The following is a description of a gene set: species: Homo sapiens Reactome Pathway: RUNX1 regulates transcription of genes involved in WNT signaling part of: Transcriptional regulation by RUNX1 The RUNX1:CBFB complex directly regulates transcription of at least two components of WNT signaling. In association with its co-factor FOXP3, the RUNX1:CBFB complex stimulates transcription of the RSPO3 gene, encoding a WNT ligand that is implicated as a breast cancer oncogene. In association with the activated estrogen receptor alpha (ESR1), the RUNX1:CBFB complex stimulates the expression of AXIN1, which functions as a regulator of WNT signaling., and this is the list of marker genes: RSPO3, RUNX1, CBFB, AXIN1, ESR1, FOXP3